The following is a description of a gene set: from publication Lund R, Aittokallio T, Nevalainen O, Lahesmaa R (PMID 14607935) Th1 and Th2 cells arise from a common precursor cell in response to triggering through the TCR and cytokine receptors for IL-12 or IL-4. This leads to activation of complex signaling pathways, which are not known in detail. Disturbances in the balance between type 1 and type 2 responses can lead to certain immune-mediated diseases. Thus, it is important to understand how Th1 and Th2 cells are generated. To clarify the mechanisms as to how IL-12 and IL-4 induce Th1 and Th2 differentiation and how TGF-beta can inhibit this process, we have used oligonucleotide arrays to examine the early polarization of Th1 and Th2 cells in the presence and absence of TGF-beta after 0, 2, 6 and 48 hours of polarization. Genes down-regulated in CD4 T cells: untreated (0h) versus activated by anti-CD3 and anti-CD28 and then stimulated by IL-12 (48h). studied in species Homo sapiens Human Gene Set: GSE2770_UNTREATED_VS_IL12_TREATED_ACT_CD4_TCELL_48H_DN, and this is the list of marker genes: STAC2, CFH, RPRD1B, GPR153, HHAT, EXOC1, WDR77, UBE2L6, SNX5, SPATA2L, PLPPR2 (NCBI Gene Id 64748), CCNE2, MAF, TRNAU1AP, PDE4DIP, MTG1, WRNIP1, PPBP, PNO1, SCFD1, ORC4, SRSF7, UBE2B, MEMO1, TRIM5, TGDS (NCBI Gene Id 23483), IKZF2, SDC4, RAB1A, SSR2, AQR, PPP4R3B, EEF1AKMT2, SBNO1, CCNG1, BRIX1, UBA5, CDK7, ANXA5, SLC15A4, TAS1R1, NPR1, RAB39A, TSPAN14, GABRD, LAS1L, MED21, EPS8, NLRP9 (NCBI Gene Id 338321), PBK, DLD, RPS19BP1, UCHL5, FGB, ABCD3, PHLPP1, YWHAE, JAK2, SCAF8 (NCBI Gene Id 22828), SMARCAD1, DNAJC21, VPS53, SLC35A3, NFKB1, C1QC, POLB, ZNF644, SPINK5, HNRNPLL, PURB, FAM241A, PRXL2A, MIA2, RBM18, WDR62, ARMCX3, MND1, TOGARAM1, OMD, CFAP298, GPR62, ACVR1, RNASEH2B, CCDC141, SLBP, PITPNA, HPS6, ELOC, TMEM64, CHURC1, ESF1, NTRK1, SYPL1, DLK1, CRK, LTO1, HABP4 (NCBI Gene Id 22927), PSMA3, GKAP1, SNX3, NKRF, CRELD2, MTERF3, TMEM70, USF2, MLEC, AZIN1, TOP2A, GLYR1, RNGTT, HEBP1, ZFX, DNAJC2, DRAM2, NDUFAF6, SLC12A1, PCGF6, HSD17B4, RPP25L, EBNA1BP2, LBH, HTRA1, EXOC3L1, SIRT1, SLAIN2, JPT2, EXTL3, RAD17, PCM1, DDX18, MED13, ARHGEF39, DNTTIP2, KLHL7, IREB2, ARL4C, CDK8, CCNQ, ZYX, CD164, TIMM23 (translocase of inner mitochondrial membrane 23), MATN4, PWP1, NCAPG, PSMA2, TATDN3, BARHL2, GRB2, NECTIN2, EPDR1, ATF3, PGAM1, PDE6D, DNAAF5, TNPO3, UBE2D3, STRN, MAP2K1, ANXA1, CCDC117, NOS2, PSPC1, ASXL3, ZMAT1, ZNF14, CISD1, TLCD1, SF3A3, CEP68, GTF2E1, THUMPD3, ZNF654, ALDOB, NASP (nuclear autoantigenic sperm protein), OSBP, POM121L2, WDR26, MANF, VOPP1, RLIG1, ZBTB5, HSDL2, CCAR1, SLC25A3, COP1, ARCN1, MRPL18, ACBD3, HSP90AA1, RNF11, CEP95, EIF3E, BCL2L12, CRYM, CACHD1, C14orf119, CNOT6, HELZ, SALL4, CHML